Given this list of marker genes Trp53, Rb1, Myc, Smarcb1, Cdkn2a, Bub1, Ndrg2, Msh2, here is a description of the gene set: Mouse Gene Set: MP_INCREASED_BRAIN_TUMOR_INCIDENCE Mouse genes annotated to increased brain tumor incidence (MP:0009277) retrieved from the Mouse Genome Informatics database via MouseMine species: Mus musculus from publication Motenko H, Neuhauser SB, O'Keefe M, Richardson JE (PMID 26092688)